Given this list of marker genes GNE, GFUS, RENBP, GALM, DSE, DSEL, GLCE, RPE, GALE, FUOM, RPEL1, here is a description of the gene set: studied in species Homo sapiens Human Gene Set: GOMF_RACEMASE_AND_EPIMERASE_ACTIVITY_ACTING_ON_CARBOHYDRATES_AND_DERIVATIVES Catalysis of a reaction that alters the configuration of one or more chiral centers in a carbohydrate molecule.